The following is a description of a gene set: Human Gene Set: HP_HIP_FLEXOR_WEAKNESS Reduced ability to flex the femur, that is, to pull the knee upward. species: Homo sapiens Hip flexor weakness, and this is the list of marker genes: MYOT (NCBI Gene Id 9499), COL13A1, AGRN, FLNC, CHRND, RAPSN, CHRNE, DOK7, LRP4, CHRNA1, GNE, SCN4A, AK9, MUSK, CHRNB1